The following is a description of a gene set: Genes down-regulated in T cells: control versus TX527 (hypocalemic analog of 25-hydroxyvitamin D3). Hypocalcemic vitamin D analogs are appealing molecules to exploit the immunomodulatory actions of active vitamin D in vivo. The functional modulation of dendritic cells is regarded as the key mechanism underlying their ability to regulate T cell responses. In contrast, the direct actions of vitamin D and structural analogs on T lymphocytes remain less well characterized. Microarray analysis was performed to gain insight into the direct immunomodulatory actions of TX527, a hypocalcemic vitamin D analog, on human T lymphocytes. Gene expression analysis revealed that TX527 regulated a wide variety of genes involved in different aspects of T cell function, including cellular growth and proliferation, cell death, cellular development, cellular movement and cell-to-cell signalling and interaction. studied in species Homo sapiens from publication Baeke F, Korf H, Overbergh L, Verstuyf A, Thorrez L, Van Lommel L, Waer M, Schuit F, Gysemans C, Mathieu C (PMID 21131424) Human Gene Set: GSE23984_CTRL_VS_HYPOCALEMIC_VITAMIND_ANALOG_TCELL_DN, and this is the list of marker genes: DCAF4, MAPRE2, VWA5A (NCBI Gene Id 4013), PLXNC1, CDK18, LRP1, SLC27A1, FMR1, ARF4, FAM219A, TSC1, NAGA, GPR155, MBD2, PHKA2, MICAL1, ATF6, EXTL2, SLC16A7, ENDOD1, SLC35C2, ANXA1, FAM107B, BMF, ZKSCAN4, SESN1, PKIB, ANKMY2, ERBIN, CCNY (NCBI Gene Id 219771), ARHGAP6 (Rho GTPase activating protein 6), GPR34, CST3, OXR1, TMEM120A, USP33, GALC, NIBAN1, PLEKHM1, ETV3, CEP68, TMEM135, CHST12, BSN, H1-0, TPD52, ADSS1, FRMD6, APLP2, CBLB, FRAT2, BRI3 (brain protein I3), HIPK1, EEF2K, CWC22, RASSF3, IQGAP1, MCOLN3, MMD, WASHC4, INPP5K, H1-2 (NCBI Gene Id 3006), TMEM37, SNHG10, PSENEN, CORO2A, SIAH1 (siah E3 ubiquitin protein ligase 1), HGF, CACNA1D, PIP4K2A, EVI2B, MARF1, LRRC20, TMEM35B, PADI2, EP300, TNS3, ACSS1, DGKA, GANC, RNASE4, WIPF1, SFI1, RIN2, BASP1, NSMCE4A, UBXN4, B3GALNT1, DTNBP1, NEAT1, TSPAN13, C1QL2, SLC9A9, FOXN3, TXNIP, KMT2A, PAK5, SELENOP, ITGA6, DRAM2, NSD3, RAP2A, MTA3, MFSD12, ST3GAL5, TRIAP1, TAOK3, MYCBP2, GDPD5, EYA1 (EYA transcriptional coactivator and phosphatase 1), C6orf62, GRB2, PEPD, RAB22A, RASGEF1A, NARS1, TMEM178A, VRK2, GPCPD1, SORD, DNAJC9, MACIR (macrophage immunometabolism regulator), PHF2 (NCBI Gene Id 79448), ENC1, LPXN, FCRL1, CD300LB, RMND1, AKAP10, PPP4R3B, MYO1E, ZMYND11, GPNMB, SDCBP, LONRF3, ABCB4, KTN1, ABCD2, TMEM230 (NCBI Gene Id 29058), TTC5, ST8SIA4, CKB, WWP1, PDCD4, MACROD1, KIAA1143, RASGEF1B, MIR99AHG, IL7R, CCND1, SNX8, APLN, C17orf75, IRF2, ATXN7, SLC38A9, RIMOC1, LRATD2, GCNT1, ENPP1, DENND4C, SH3BP5, CD28, HIVEP3, RAMP1, CDC37L1, SUPT20H, ITGA9, DNASE1L1, SUSD3, LAPTM5, PLEKHF2 (NCBI Gene Id 79666), CHM, SYF2, SGCB, DALRD3, ALCAM (activated leukocyte cell adhesion molecule), NCEH1, FGD3, CERT1, HMGA2, STAB2, MAP4K3, PLK2, CCDC88A, REPS2, HGSNAT, H3C14, DHRS7, WLS, MORC2, RFTN1, DUSP3, ZNF469, DPY19L1, ARHGAP18, P2RY6, PHLPP1, ABCG1, SRRM2